The following is a description of a gene set: Mouse Gene Set: GOBP_RESPONSE_TO_LEAD_ION studied in species Mus musculus Any process that results in a change in state or activity of a cell or an organism (in terms of movement, secretion, enzyme production, gene expression, etc.) as a result of a lead ion stimulus., and this is the list of marker genes: Serpina1d, Becn1, Bace1, Plscr1, Mecp2, Lct, Alad, Map1lc3a, Slc34a1, Serpina1b, Serpina1e, Ppp1ca, Dnmt3a, Ppp5c, Ncam1, Cat, Serpina1a, Serpina1c, Star (NCBI Gene Id 52131), Ppp2cb, Cldn1, Ucp2, Mapt, Fech, Ptgs2, Cdk4